Given this list of marker genes Plekha8 (pleckstrin homology domain containing, family A (phosphoinositide binding specific) member 8), Cert1, Cptp, Abca1, Gltp, Pltp, Abcb1b, Spns2, Atp10b, Abca2, Mttp, Mfsd2b, Abcb1a, Gltpd2, Pitpnb, Atp10d, Atp10a, here is a description of the gene set: studied in species Mus musculus Enables the directed movement of sphingolipids into, out of or within a cell, or between cells. Sphingolipids are a class of lipids containing the long-chain amine diol sphingosine or a closely related base (a sphingoid). Mouse Gene Set: GOMF_SPHINGOLIPID_TRANSPORTER_ACTIVITY